Given this list of marker genes TWF1, EIF4E (NCBI Gene Id 1977), C1orf52, NKIRAS2, CENPS, LPGAT1, TAX1BP1, DTNB, PBDC1, MAPK11, XPO6, NMRAL1, CDCA2, NUCKS1, SLC5A2, CGAS, ZFAND4, SEPTIN10, ANAPC15, THYN1, RAB5A, ELMOD2, DIAPH3, BMPR1A, PPM1H, SH3BGRL3, DCAKD, ASPM, AFG1L, NKG7, CDC25B, HAUS3, RTEL1 (regulator of telomere elongation helicase 1), ARPC2, ELMO3, YKT6, FAM174C, NHP2, CENPE (NCBI Gene Id 1062), ERH, PIK3CD, MAPK6, DDIAS (DNA damage induced apoptosis suppressor), HECW2, PSMD14, CFAP20, SAPCD2, HMGXB4, EIF1B, HOXA3, RRS1, E2F8, OTOS, EIF2D, GORASP2, SMDT1, KAT7, KIF18B, CIT, TNFAIP8, GCSH, PPP1R18, TLR1, RRP9, CCDC146 (NCBI Gene Id 57639), PSMD9, ERRFI1, STIL, PCOLCE, RPS27L, TPD52, ST3GAL4, SP6, MAP3K2, NUDT4, UBL4A, KLF10, AKAP1, ALKBH4, ITM2C, NBEA, GCN1, CCL24, FAM20B, GCG, TOMM6, RREB1, CDC6, ENPP4, CCT3, MCM2, FLII, TDRD7, APOBEC4, ERCC6L, OSBPL3, OSBPL5, ARHGEF10, SIK3, COPS7A, RALA, GTF2A1, MFSD5, MRPS33, AFG3L2, TPGS2, WRAP73, PBX3, GMPPB, COPZ1, YY1, IL4R, NR1H2, NUP155, TSPAN14, OXSR1, ARSI, ZBTB8A, TRAIP (NCBI Gene Id 10293), LAP3, PKIB, EIF2A, KRT80, GCSAM, ANP32B, GPR83, BSG, IDO2, UBE2N, YRDC (yrdC N6-threonylcarbamoyltransferase domain containing), AGA, RUVBL1, RSAD2, SH2B1, ENTPD3, ESYT1 (NCBI Gene Id 23344), KRAS, UBXN11, MTX2, PIK3R5 (phosphoinositide-3-kinase regulatory subunit 5, NCBI Gene Id 23533), PPP1R8, RAP1B, FEN1, HMCES, CAMSAP3, CDK6, UCHL5, RAP1GAP2, CENPF, WBP4, CEP152, PRR11, HSD17B14, KYAT3, TMEM177, CASP3, NSDHL, HSPA14, CAPN2, LGALS9B, RYK, ANKRD29, SIK1, SIPA1L1, SLC35A1, GLRX, COL6A3, AK4, ZNF277, CEP72, MINDY1, GPD2, DDX20, NUP93, STOML2, SLX4, ISY1, PPP6C (protein phosphatase 6 catalytic subunit), MX2, CHCHD4, AKAP7, SLC29A1, MYO16, TEDC1, TRIM8, BID, MFSD2A, SMC2, RAP1A, UGGT1, PTPN20, XXYLT1, PRF1, ESPL1, DGCR8, SLC6A4, BAK1, ACTG1, VIM, NSMCE2, here is a description of the gene set: Multipotential naïve CD4+ T cells differentiate into distinct lineages including T helper 1 (Th1), Th2, Th17, and inducible T regulatory (iTreg) cells. The remarkable diversity of CD4+ T cells begs the question whether the observed changes reflect terminal differentiation with heritable epigenetic modifications or plasticity in T cell responses. We generated genome-wide histone H3 lysine 4 (H3K4) and lysine 27 (H3K27) trimethylation maps in naïve, Th1, Th2, Th17, iTreg, and natural (n)Treg cells. We found that although modifications of signature cytokine genes (Ifng, Il4, and Il17) partially conform to the expectation of lineage commitment, critical transcription factors such as Tbx21 exhibit a broad spectrum of epigenetic states, consistent with our demonstration of T-bet and IFN-gamma induction in nTreg cells. Our data suggest an epigenetic mechanism underlying the specificity and plasticity of effector and regulatory T cells and also provide a framework for understanding complexity of CD4+ T helper cell differentiation. from publication Wei G, Wei L, Zhu J, Zang C, Hu-Li J, Yao Z, Cui K, Kanno Y, Roh TY, Watford WT, Schones DE, Peng W, Sun HW, Paul WE, O'Shea JJ, Zhao K (PMID 19144320) species: Homo sapiens Genes up-regulated in comparison of Th2 cells versus Th17 cells. Human Gene Set: GSE14308_TH2_VS_TH17_UP